The following is a description of a gene set: Human Gene Set: WP_DISORDERS_OF_BILE_ACID_SYNTHESIS_AND_BILIARY_TRANSPORT Disorders of bile acid synthesis and biliary transport species: Homo sapiens, and this is the list of marker genes: SLCO1B1, SLC10A2, SCP2, CYP8B1, ACOX2, ABCD3, ABCC4, CYP27A1, ATP8B1, SLC10A1, SLC27A5, CYP7A1, SLC51B, ABCB11, BAAT, ABCB1, AKR1D1, SLC27A2, AKR1C4, ABCC3, SLC51A, ABCB4, HSD17B4, ABCC2, HSD3B7, SLCO1B3, CYP7B1, AMACR, FABP6